The following is a description of a gene set: Diverse molecules of host-cell origin may serve as endogenous ligands of Toll-like receptors (TLRs) (Erridge C 2010; Piccinini AM & Midwood KS 2010). These molecules are known as damage-associated molecular patterns (DAMPs). DAMPs are immunologically silent in healthy tissues but become active upon tissue damage during both infectious and sterile insult. DAMPs are released from necrotic cells or secreted from activated cells in response to tissue damage to mediate tissue repair by promoting inflammatory responses. However, DAMPs have also been implicated in the pathogenesis of many inflammatory and autoimmune diseases, including rheumatoid arthritis (RA), cancer, and atherosclerosis. The mechanism underlying the switch from DAMPs that initiate controlled tissue repair, to those that mediate chronic, uncontrolled inflammation is still unclear. Recent evidence suggests that an abnormal increase in protein citrullination is involved in disease pathophysiology (Anzilotti C et al. 2010; Sanchez-Pernaute O et al. 2013; Sokolove J et al. 2011; Sharma P et al. 2012). Citrullination is a post-translational modification event mediated by peptidyl-arginine deaminase enzymes which catalyze the deimination of proteins by converting arginine residues into citrullines in the presence of calcium ions. studied in species Homo sapiens Reactome Pathway: Regulation of TLR by endogenous ligand part of: Toll-like Receptor Cascades, and this is the list of marker genes: CD36, APOB, HMGB1, TLR1, FGB, FGA, LY96, S100A8, GSDMD, TLR6, S100A1, TLR7, SFTPD, TLR2, CD14, SFTPA2, S100A9, LBP, TLR4, SFTPA1, FGG, GSDME